The following is a description of a gene set: An abnormal appearance of the long bones with resemblance to a dumbbell, a short bar with a weight at each end. That is, the long bone is shortened and displays flaring (widening) of the metaphyses. species: Homo sapiens Human Gene Set: HP_DUMBBELL_SHAPED_LONG_BONE Dumbbell-shaped long bone, and this is the list of marker genes: SLC26A2, COL11A1, SLC35D1, CCN2, COL11A2, INPPL1, COL2A1 (NCBI Gene Id 444981), TRPV4